Given this list of marker genes TCF21, ZFAND1, GUCY1A1, CALN1, MSR1, ELAVL2, NDNF, ERAP1, CCNL1, PCDHA9, ARAF, TIMM8B, CTNND2, CCDC80, NCOA1, PTPRG (NCBI Gene Id 5793), CDH11, GPM6B, C14orf39, ZIC4, PCDHA11, MARS2, MAG, TPM3, C15orf40, CD302, PEG10, TCEAL9 (transcription elongation factor A like 9), RO60, ULK1, ABCD2, C9orf72, MARCKS, DNHD1, DNAJA4, TOX3, HCN1, PCSK6, CAAP1, PLAG1, RAB11A, CALCRL, SIPA1L2, THAP1, OTOGL (NCBI Gene Id 651200), TMEM97, ELAVL3, ACTC1, PRKCD, PTAR1, NFAT5, STEAP2, PPP6R3, FAM98A, TNFRSF11B, ABCC9, TAFA1, ZDHHC23, LCLAT1, GALE (NCBI Gene Id 2582), NHLH1, LRP2BP, ANKRD44, CLASP2 (cytoplasmic linker associated protein 2), FSIP1, BACH2, STAB1, DLX1 (NCBI Gene Id 1745), VSNL1, UGT8, UNC5A, COMMD3-BMI1, RNF212B, TRPS1, FOXJ3, PCDHA13, VAPA, FSTL3, RUNX2, NR2F2, DUSP4, PTP4A2, ZNF510, TP53RK, SPIN1, RAP1GAP2, PHF13, VPS36, HIGD1A, TUT7, TTC5 (tetratricopeptide repeat domain 5), CMPK1, WSB1, SMARCAD1, SCN8A, PLEKHA5, EXT1, ABI1, YWHAG, SPATA22, E2F7, PCDHA4 (NCBI Gene Id 56144), PIAS2, CACNB2, PCDHA2, TNPO1, PCLO, PCDHA3, TET1, INTU, GFM2, PCDHA8, B3GALT2, CXCL16, MSANTD2, CRISPLD1, TGFB2 (transforming growth factor beta 2), PCDHA6, PCDHA5, SLC35F1, TRIM43B, LRBA, SACS, PPIL4, TOGARAM1, OR51E2, RB1, HTR4, STK26, KMT5B (NCBI Gene Id 54794), UBE2B (NCBI Gene Id 7320), CREG2, IREB2, TRIM43, KDM6A, POPDC3, THRB, RIC1, CLIC4, ELOVL2, CCDC190, SNX16, ZSCAN23, BCL11B, DENND10, PARP8, PCDHAC2 (NCBI Gene Id 92387), SKAP2, DOK6, HS6ST3, NAA15, MARK1 (NCBI Gene Id 55887), EIF2S1, KCNH5, UNC5C, APC, HNRNPR, IL2RA, SIPA1L1, RASAL2, GLYAT, SLCO3A1, B3GALNT2, ZNF420, PCDHA1, APPBP2, HNRNPD, YIPF5, SLC20A1, KCNN2, CDK6, ENTPD3, AMMECR1, PDZD8, PLEKHG3, PCDHA10, BNIP2, BBX (BBX high mobility group box domain containing), LY75-CD302, GCG, FUT9, PHIP, RAB11FIP2, LARP1B, LCORL, ZNF514, AFTPH, SRGAP2C (SLIT-ROBO Rho GTPase activating protein 2C), SLBP, ZIC3, ETV1, MTMR10, ABTB2, COX15, MOB1A, QSER1, PCDHAC1, SRGAP2B, TXN, CALU, RNF24, SMAD1, PCDHA7, RBFOX1, TFEC, PLEKHA3, ITM2A, PKP4, ANXA2R, PCDHA12 (NCBI Gene Id 56137), SFRP5, BHMT, CLVS1, FAM3C (FAM3 metabolism regulating signaling molecule C), IL17RB, here is a description of the gene set: Human Gene Set: MIR3942_5P from publication Chen Y, Wang X (PMID 31504780) species: Homo sapiens Genes predicted to be targets of miRBase v22 microRNA hsa-miR-3942-5p in miRDB v6.0 with MirTarget v4 prediction scores > 80 (high confidence targets).